Given this list of marker genes Txnl1, Vav3, Arhgef39, Abcd3, Rhou, Net1, Plxnb1, Racgap1, Arhgap15, Rhod, Rnf20, Rasgrf2, Plekhg1, Iqgap1, Emd, Scfd1, Peak1, Cdc42ep4, Rhoq, Dock7, Dsg2, Trio, Sptbn1, Srgap3, Pld2, Ptpn13, Ralgapa1, Cltc, Rhob, Syde1, Depdc1b, Fam169a, Fam91a1, Abr, Nsfl1c, Rhoa, Pak4, Sh3bp1, Cyfip1, Arl13b, Plekhg2, Rhoj, Pak2, Frs3 (fibroblast growth factor receptor substrate 3), Amigo2, Pik3ca, Lrrc1, Fgd2, Itsn1, Cavin1, Rac3, Rock1, Cdc42ep2, Ckap4 (cytoskeleton-associated protein 4), Steap3, Mpp7, Gmip, Ncf2, Prag1 (PEAK1 related kinase activating pseudokinase 1), Dock9, Map3k11, Arhgdig (NCBI Gene Id 14570), Pde5a, Farp2, Pik3r2, Tpm4, Pak6, Twf1, Phip, Mcam, Arhgef28, Acbd5, Noxo1, Grb2, Plxna1, Dlg5, Cpne8, Armcx3, Pard6a, Cep97, Arhgef11, Rnd2 (NCBI Gene Id 11858), Ktn1, Hspe1-rs1, Arhgap1, Bcap31, Letm1, Bcr, Sema4f, Pak1, Arhgef12, Spata13, Pgrmc2, Nipsnap2, Arap2, Efhd2, Gps1, Abl2, Arhgap30, Pkp4, Arhgap29, Jag1, Pak5, Hint2, Dbt, Arhgap28, Nck2 (non-catalytic region of tyrosine kinase adaptor protein 2), Daam1 (NCBI Gene Id 69600), Ndufs3, Tpm3, Fam13b, Cops2, Ngef, Diaph1 (NCBI Gene Id 28110), Nck1, Epha2, Arhgap24, Ophn1, Vamp3, Msi2, Slc4a7, Stard8, Ubxn11, Dsg1a, Stmn2, Akap12, Maco1 (NCBI Gene Id 77906), Prex2, Rhoh, Arhgap4, Myo9b, Sowahc, Cdc42ep3, Arhgap12, Arhgef5 (Rho guanine nucleotide exchange factor 5), Nhs, Itgb1, Sos2, Stbd1, Cybb, Kctd13 (potassium channel tetramerisation domain containing 13), Vav1, Brk1, Arap1, Arhgap6, Samm50, Stx5a, Dsp, Scrib, Whamm, Zfp512b, Cftr (cystic fibrosis transmembrane conductance regulator), Frs2, Bltp3b, Rnd3, Arhgef18, Pkn1, Ankrd26, Diaph3, Spen, Zap70, Cdc42bpa (CDC42 binding protein kinase alpha), Flot1, Arhgap17, Wdr6, Stk38 (serine/threonine kinase 38), Sh3rf1, Arhgap5, Grb7, Arhgap21, Lman1, Sptan1, Cdc42ep1, Ddrgk1, Arhgdib, Cyba (cytochrome b-245, alpha polypeptide), Pard6b, Ncf1, Picalm, Tmem59, Rhof, Vangl1, Anln (NCBI Gene Id 97521), Pkn3, Srrm1, Mtx1, Arhgef2, Tor1aip1, Cct2, Nudc, Tra2b, Fgd1, Tmem87a, Actb, Srgap1 (NCBI Gene Id 67744), Tnfaip1, C1qbp, Arhgap44 (Rho GTPase activating protein 44), Rab7, Ccdc115, Wdr11, Tex2, Gopc, Rapgef1, Gna13, Stard13, Arhgap35, Cul3, Pcdh7, Lamtor1, Vapb, Arhgap18, Cpsf7, Rbm39, Cdc42bpb, Actg1, Aaas, Wasf2, Tuba1b, Dock11, Lbr, Arfgap3, Ralbp1, Garre1 (NCBI Gene Id 77061), Tjp2, Arhgef7, Fermt2, Usp9x, Ect2, Baiap2l2, Rhobtb2, Kidins220, Mcf2, Gja1, Kalrn, Arhgap20, Atp6ap1, Dock4, Dock5, Slitrk3, Iqgap3, Tmod3, Pkn2, Arhgap39, Ocrl, Arhgef19, Dock10, Pik3r1, Obscn, Ddx39b, Hsp90ab1 (heat shock protein 90 alpha (cytosolic), class B member 1), Myo9a, Baiap2, Nckap1l, Fam83b, Flot2, Arhgap8, Dock6, Wasf1, Rac1, Plekhg6, Arhgap31, Plekhg5, Golga2, Rhoc, Fnbp1, Arhgef9, Arhgap42, Git1, Csk, Sos1, Arhgap26, Fmnl2, Dock2, Arhgef6, Noxa1, Cops4, Fmnl3, Fam13a, Nisch, Itsn2, Ckb, Mcf2l, Slc1a5, Farp1, Abi1, Cdc37, Syde2, Taok3, Rhpn2, Nox1 (NADPH oxidase 1), Dock8, Stk10, Arhgef25, Fgd3, Arhgap40, Arhgap27, Esyt1, Slk, Filip1, Akap13, Snap23, Ndufa5, Tfrc, Stam2, Emc3, Pik3r3, Rtkn, Arhgap10, Ncf4, Fgd4, Arhgap32, Gfod1, Faf2, Wwp2, Cyfip2, Arap3, Rbmx, Ykt6, Diaph2, Def6, Rhov, Vim, Myo6, Arhgef26, Osbpl11, Erbin, Abi2, Als2, Arhgap23, Cdc42, Actc1, Ccdc88a, Arhgap9, Swap70, Hspe1, Arhgef15, Nckap1, Senp1, Muc13, Ankle2, Git2 (GIT ArfGAP 2), Cct6a, Ankfy1, Iqgap2, Rasal2, Rhobtb1, Dock1, Plekhg3, Arhgef16, Plxnd1, Arhgap45 (NCBI Gene Id 70719), Arhgap22, Tagap, Arhgef10, Dnmbp, Baiap2l1, Dlc1, Capzb, Ccp110, Slitrk5, Arhgap19, Add3, Pak3, Lmnb1, Basp1, Stam, Fam135a, Wasf3, Jup, Hnrnpc, Srgap2, Rnd1, Nox3, Rhog, Rras2, Hgs, Shmt2, Prex1, Stom, Chn1, Vav2, Cpd, Arhgap33, Tiam2, Rac2, Golga3, Rock2, Stip1, Dst, Actn1, Chn2, Arhgef1, Hmox2, Rbbp6, Trip10, Arhgap11a, Kif14, Elmo2, Rhpn1, Aldh3a2, Cav1, Ptk2b, Mtmr1, Arhgap25, Fgd5, Vcp, Epsti1, Vangl2, Arhgdia, Hsp90aa1, Arhgef17, Mospd2, Cct7, Mtr, Arhgef3, Lck, Fmnl1, Vrk2, Arhgef10l, here is a description of the gene set: studied in species Mus musculus Mouse Gene Set: REACTOME_RHO_GTPASE_CYCLE RHO GTPase cycle